Given this list of marker genes Arid1a, Smarce1, Rybp, Phc2, Auts2, Pbrm1, Yaf2, Smarcd1, Pcgf5, Actl6a, Ring1, Cbx8, Smarcb1, Bmi1, Csnk2a2, Rnf2 (NCBI Gene Id 98537), Smarcd2, Cbfb, Phc3, Phc1, Cbx4, Actl6b, Smarcc1, Scmh1, Csnk2b, Hipk2, Ep300, Smarcd3, Cbx6, Cbx2, Smarcc2, Smarca4, Csnk2a1, here is a description of the gene set: RUNX1 interacts with co-factors whose precise effect on RUNX1 targets is not known species: Mus musculus Mouse Gene Set: REACTOME_RUNX1_INTERACTS_WITH_CO_FACTORS_WHOSE_PRECISE_EFFECT_ON_RUNX1_TARGETS_IS_NOT_KNOWN